The following is a description of a gene set: Vertebral compression fracture Human Gene Set: HP_VERTEBRAL_COMPRESSION_FRACTURE studied in species Homo sapiens, and this is the list of marker genes: SERPINH1, DKK1, ATRX, NFATC2, BRAF, USP48, TENT5A, P4HB, SBDS, SPARC, XYLT2, DDRGK1, FKBP10, PPIB, DNAJC21, TNFRSF11A, GBA1, CDH23, TP53, CREB3L1, AIP, SCARB2, USP8, NR3C1 (NCBI Gene Id 389335), WNT1, CCND1, COL1A1, CRTAP, MESD, SMS, P3H1 (NCBI Gene Id 64175), LRP5, MMP2, EFL1, WNT3A, NOTCH2, GPR101, GORAB, UROS, SERPINF1, PYCR1